The following is a description of a gene set: Human Gene Set: GCM_RAF1 studied in species Homo sapiens Neighborhood of RAF1 Neighborhood of RAF1 v-raf-1 murine leukemia viral oncogene homolog 1 in the GCM expression compendium, and this is the list of marker genes: HNRNPA1, UBE2D3, HNRNPC, HNRNPD, FUS, CAPRIN1, SF1, DR1 (NCBI Gene Id 1810), MAZ, SLC25A3 (NCBI Gene Id 5250), RAF1, HNRNPU, TRIM28, KHDRBS1, TAF9, SRSF4, LMNB2, SET, DRAP1, PABPC1, PCM1, VAMP7, ILF2, PCBP2, GPER1, IDUA, CSNK2B, H3-3B, PTGES3, DDX39B, HNRNPL, EIF4A1 (eukaryotic translation initiation factor 4A1), NONO, GPS2, DDX5, DNAJC7, USP7 (ubiquitin specific peptidase 7), DHPS, PCBP1, PRMT1, CFL1, MARS1, HMGN1